The following is a description of a gene set: from publication Cui A, Huang T, Li S, Ma A, Pérez JL, Sander C, Keskin DB, Wu CJ, Fraenkel E, Hacohen N (PMID 38057668) studied in species Mus musculus Genes negatively differentially expressed in cell type: pDC (plasmacytoid dendritic cell) upon treatment with cytokine: IL-10 in mouse lymph nodes in vivo. Cytokines mediate cell-cell communication in the immune system and represent important therapeutic targets. A myriad of studies have highlighted their central role in immune function, yet we lack a global view of the cellular responses of each immune cell type to each cytokine. To address this gap, the authors created the Immune Dictionary, a compendium of single-cell transcriptomic profiles of more than 17 immune cell types in response to each of 86 cytokines (>1,400 cytokine-cell type combinations) in mouse lymph nodes in vivo. A cytokine-centric view of the dictionary revealed that most cytokines induce highly cell-type-specific responses. For example, the inflammatory cytokine interleukin-1β induces distinct gene programmes in almost every cell type. A cell-type-centric view of the dictionary identified more than 66 cytokine-driven cellular polarization states across immune cell types, including previously uncharacterized states such as an interleukin-18-induced polyfunctional natural killer cell state. Mouse Gene Set: CUI_PDC_IL10_RESPONSE_DN, and this is the list of marker genes: Leng8, Upb1, Uba52, Igbp1, Btg2, Tsc22d3 (NCBI Gene Id 14605), Cmah, Cox7a2l, Cirbp, Eif3e, Eef1a1, Bin1, Atp2a3, Ypel3, Septin4, Cd209a, Pdcd4, Tmem163 (NCBI Gene Id 72160), Ccr2, S100a10, Spns3 (NCBI Gene Id 77577), Eif3f, Naca, Khk, Ptprs (protein tyrosine phosphatase receptor type S), Padi1, Haus3, Timp2, Tifab, Arl5c, Hvcn1, S1pr4, Pafah1b3, Mxd4, Pnck, Cdip1, Spag7, Il16, Rnf149, Tpm1, Syk, Ptprf, Pold4, Klf2, Gpi1, Ramp1, Pgls, Zyx, Zbtb20, Zfp36l1, Nop53, Yipf1, Rgs10, Zfhx3 (zinc finger homeobox 3), Nsmce2, Cdc14b, Svbp, Grina, Zfp945, Smim14, Gna11, Eef2, Serinc5 (serine incorporator 5), Maf1